The following is a description of a gene set: studied in species Mus musculus Any process that stops, prevents or reduces the frequency, rate or extent of cellular respiration. Mouse Gene Set: GOBP_NEGATIVE_REGULATION_OF_CELLULAR_RESPIRATION, and this is the list of marker genes: Apoc3, Tnf, Dnajc15, Pde2a, Ppif, Rhoa, Trap1, Mlxipl, Actn3